The following is a description of a gene set: species: Homo sapiens from publication Yevshin I, Sharipov R, Kolmykov S, Kondrakhin Y, Kolpakov F (PMID 30445619) Human Gene Set: ZNF19_TARGET_GENES Genes containing one or more binding sites for (ZNF19) in their promoter regions (TSS -1000,+100 bp) as identified by GTRD version 20.06 ChIP-seq harmonization., and this is the list of marker genes: GLG1, MTREX, RND1, CASC3 (NCBI Gene Id 22794), TTC1, CROCCP3, STAT6, HNRNPA2B1, STX6, KLHDC9, GOLM2, CBX3, DHX29